Given this list of marker genes MADD, TFAP2B, TMEM270, HNRNPH2, DPF2, KRAS, PTDSS1, VPS51, KCNN3, RASA2, SOS2, PPP3CA, GALNT2, KDF1, NEXMIF, KCNK9, KDM6B, FIBP, SHOC2, PAK3, UGDH (UDP-glucose 6-dehydrogenase), HUWE1, CBL, CILK1, ADAMTS2, KCNE5, CIT, AFG2B, CUL4B, SUPT16H, LTBP1, TOE1, TCF4, KCNJ8 (NCBI Gene Id 3764), GPR101 (G protein-coupled receptor 101), PHGDH, FBXO31, CWC27, CDK13, ARID1B, DVL1, WBP4, AP1S2, COG6, ANTXR1, SPRED2, CAMTA1, CDC6, TBC1D24, SPTBN1, TRAF6, METTL27, RNU4-2 (NCBI Gene Id 26836), ORC4, SET, MRAS, ADNP, SMARCA2, NEU1, AFF2, NF1, IFT52, FTSJ1, TWIST2, GNPTAB, EIF4H, MEG3, SYNGAP1, EHMT1, NRAS, DPYSL5, MAN1B1, SLC35A2, CA2, LARP7, EDEM3, DEAF1, STRADA, PTPN11, PPP1R21, KIF11, LTBP3, SMARCC2, RNU12, KMT2D, TMEM147, DNAJC30 (DnaJ heat shock protein family (Hsp40) member C30), GRIA3, H4C5, AP2M1, CCDC8, SC5D, AMMECR1, RSPRY1, ATP6V1B2, NOG, KDM6A, STAG2 (STAG2 cohesin complex component), AFF3, RET, ZBTB20, WDR26, FKBP6, ABCC9, SOX11, SCN1A, ARID1A, PPP1CB, KMT2C, NAGA, ELN, KIFBP, GJA8, FRA10AC1, SMS (spermine synthase), EXOSC5, ATRX, EDARADD, KAT8, XYLT1 (xylosyltransferase 1), EDAR, RAF1, ZMYM2, GMNN, MYCN, SETBP1, ANKRD11, NONO, KIF15, RFC2, BRAF, ADAT3, INSR, LIMK1, GLA, RIN2, SOS1, RBMX, GTF2I, TASP1, CLIP2, RTL1, GPC4, RPS23, SMG9, ORC1, SH3PXD2B (SH3 and PX domains 2B), FBXO11, NCF1, SRD5A3, CHD2, RPS7, SMARCD1, BAZ1B, NANS, PIGL, CDKL5, STX1A, GNS, TSPEAR, FOXP1, HECW2, FHL1, DENND5A, SMC5, KCNH1, CDH11, PCDHGC4, COL11A1, KREMEN1, COG7, DYRK1A, TFE3, RPS6KA3, ADAM22, ECM1, CCDC47, BRCA1, NAA10, AIP, GTF2IRD2, GRIA1, IDS, SNX14, PTH1R, ERMARD, HRAS, POU4F1, FRMD4A, SCUBE3, GTF2IRD1, IDUA, TAF4, VPS37D, OFD1, CNTNAP1, SPEN, SOX4, VPS33A, RBL2, GPC3, HDAC4, BCAS3, HECTD4, NAA20, ARID2, CNTNAP2, OBSL1, NFIX, CACNA1I, VPS13B, RNF2, AMER1, TBCK, FLNA, MLXIPL, JARID2, SMARCA4, GJA5, YY1, TMEM53, EXOSC1, ZEB2, THOC6, MOCS2, LZTR1, RNU4ATAC, GNAI1, EIF2S3, AUTS2, RIT1, SETD1B, FBN1, MED12, PUS7, TBL2, RNF135, DLK1, PRIM1, ACSL4, AP4S1, DOCK7, SLC6A1 (NCBI Gene Id 6529), KAT5, APC, SOX18, AIMP2, MINPP1, MCM5, PSMB8, CUL7, CDC45, EDA, P4HTM, MOCS1, PIDD1, SIN3A, B9D1, SLC2A1, RHOBTB2 (Rho related BTB domain containing 2), ACER3, SMARCB1, SEC31A, OGT (O-linked N-acetylglucosamine (GlcNAc) transferase), KDM4B, AGA, KIF7, ZNF699, RRAS2 (RAS related 2), USP9X, SMARCE1, BUD23, NSUN2, ORC6, EBF3, RRAS, FUCA1, ERF, TRIO, CDT1, SMG8, EPG5, GLI2 (NCBI Gene Id 50806), here is a description of the gene set: Thick vermilion border Human Gene Set: HP_THICK_VERMILION_BORDER studied in species Homo sapiens Increased width of the skin of vermilion border region of upper lip.